Given this list of marker genes Rbmy (RNA binding motif protein, Y chromosome), Tsx, Srd5a2, Rbmyf9, Bmp5, Adam29, Nhlh2, Adam4, Rbmyf3, Nupr1, Gata6, Bcl2, Rbmyf1, Ing2, Aspm, Tlr9, Sfrp1, Asb1, Mcidas, Hoxa10, Bmp6, Rbp4, Wnt5a, Odad3, Adam32, Ren1, Rara, Wt1, Arid5b, Wnt4, Star, Rbmyf2, Msh2, Esr1 (estrogen receptor 1 (alpha)), Ctsl (NCBI Gene Id 320361), Hoxd13, Stat5a, Adam6b, Atn1, Ace, Insr, Kdr, Amh, Asmt, Dhcr24, Insl3, Tcf21, Fgf10, Acvr2a, Greb1l, Jmjd1c, Insl6, Adam39, Scaper, Gata4, Ahsg, Dmrt1, Nr5a2, Fshr, Adam1b, Dmrt3, Adam20, Dnaaf11, Zfpm2, Gfra1, Rab13, Adam15, Adam34, Adam5, Scx, Tfpt (NCBI Gene Id 69714), Shh, Nudt1, Gata3, Adam2, Kif18a, Mas1, Adam26a, Nr0b1, Bok, Tgfbr1, Lhcgr, Rbmyf5, Wnt9b, Plekha1, Eif2s3y, Rec8, Arid4b, Rhobtb3, Rxfp2, Six4, Rad21l, Fkbp4, Klhl10, Adam3, Flna, Icam1, Cftr, Adam18, Ar, Fanca, Nkx2-1, Ccno, Kitl, Mmp14, Ntrk1, Akap9, Adgrg1, Tesc (NCBI Gene Id 80653), Sema3a, Sox9, Tex19.1, Nup210l, Gmnc, Bax, Rrm1, Nkx3-1, Dhx37, Ercc1, Inhbb, Adam6a, Esr2, Ctnnb1, Bcl2l2, Fgf8 (NCBI Gene Id 14179), Sry, Crkl, Gata1, Hoxa13, Rbmyf7, Gm4787 (NCBI Gene Id 541588), Mir455, Tgfb2, Ago4, Sf1, Ubb, Kcne1, Tex15, Cd2ap, Ccnd1, Kdm5a (lysine demethylase 5A), Hsd17b4, Mir202, Mamld1, Smad9, Fndc3a, Rnase10, Hoxa11, Abcb1a, Sox8, Pitx2, Eif2s2, Lrp2, Sdc1, Adam34l, Inha, Pdgfra, Tnfsf10, Dhh, Tex11 (NCBI Gene Id 83558), Hoxa9, Sox3, Tbc1d20, Adam21, Map7, Safb2, Hmgb2, Prdx4, Gja1, Mir184 (microRNA 184), Bik, Adrm1, Patz1, Cited2, Adam30, Spata2, Sfrp2, Hmga2, Smad5, Il1a, Stat5b, Tlr3, Lhfpl2, Bcl2l11, Adam26b (NCBI Gene Id 382007), Ncoa1, Rbmyf6, Kit, Csmd1, Cbl, Cyp1b1, Spink2, Brip1, Sox2, H3f3b, Adam24, Adam25, Mir193a, Tex19.2, Bmpr1a, Tmf1, Arid4a, Fer, Fgf9, Lhx9, Inhba, Rbmyf8, Amhr2 (anti-Mullerian hormone type 2 receptor), Adam1a, Nr5a1, Ctnna1, Bcl2l1, Dnaaf3, Sycp2, Wnt2b, Gm17266, Ybx3, Lgr4, Fshb, Smad4, Mir144, Sgpl1, Tbx3, Wdr48 (NCBI Gene Id 67561), Atrx, here is a description of the gene set: Mouse Gene Set: GOBP_MALE_SEX_DIFFERENTIATION The establishment of the sex of a male organism by physical differentiation. species: Mus musculus